Given this list of marker genes Cdh9, Gm18582, Cdh10, Hnrnpa1l2-ps2, Gm8318, Gm2638, Gm25976, Cdh18, C030047K22Rik, Gm23980, 4921515E04Rik, Gm35496 (NCBI Gene Id 102639102), Gm25711, Gm41277, Cdh12, Gm2611, Gm18533, Gm6533, Gm19207, Gm8341, Acot10, Polr2d-ps1, Gm18741, Gm18532, Gm8408, Gm19371, Gm8328, Gm19840, here is a description of the gene set: Mouse Gene Set: chr15A2 studied in species Mus musculus